The following is a description of a gene set: species: Homo sapiens In this study, we examined differential gene expression in naïve human CD4+ T cells, as well as in effector Th1, Th17-negative and Th17-enriched CD4- T cell subsets. We observed a marked enrichment for increased gene expression in effector CD4+ T cells compared to naive CD4+ among immune-mediated disease oci genes. Within effector T cells, expression of disease-associated genes was increased in Th17-enriched compared to Th17-negative cells. We used microarray to examine the gene expresssion profile and level of human naïve, Th1 and effector T cell subsets. from publication Zhang W, Ferguson J, Ng SM, Hui K, Goh G, Lin A, Esplugues E, Flavell RA, Abraham C, Zhao H, Cho JH (PMID 22715389) Human Gene Set: GSE32901_TH1_VS_TH17_NEG_CD4_TCELL_DN Genes down-regulated in CD4 T cells: Th1 versus Th17 negative., and this is the list of marker genes: TUBD1, TNFAIP8, IGHG3, HSD17B7, FAM43A, MSRB2, BCAR3, LY6G5C, HTR6, LY6D, MRPL55, DYNLT2B (dynein light chain Tctex-type 2B), INTS2, SLPI, DRP2, CHMP4C, CBX5, ACP1, CASP4, MX1, USP26, MPV17, MS4A3, CDC20, CD24, KRTAP5-4, PDZRN4, ADSS1, CCDC184, ADORA2B, SLC5A3, CAPG, CLN5, MIR187, CPLX3, KRTDAP, MOV10L1, SSX2IP, BACE2, HPGDS, IRAG2, KRT24, SWAP70, HLF, DNAJC5G, TMOD2, RHOU, BID, GPR68, LY86, EGR2 (early growth response 2), TLE1, ADGRB1, COPZ2, TMEM126A, NDC80, MARCKSL1, RFC2, NAPSA, DMPK, IL1RAPL2, DNAJC22, GSTM1, CKS1B, CLMN, DSTN, CES1, NPS, CD163L1, PGK2, UPP1, GPR37, CFAP44, NASP, CCL4, GPR137C, NELFCD, JPT2 (NCBI Gene Id 90861), MIR212, SLITRK3, FIGNL1, ARL2, ZCWPW2, FASTKD3 (NCBI Gene Id 79072), DNAJB2, CWH43, CD19, CDCA8, FAM167B, SEMA4C, MYL1, TNFSF9, SNORA19, DCC, EME1, NTRK3, RAD54L, PHEX, CD79A, NELL1, USHBP1, FCMR, MIR370, SLC4A4, CNP, SH3TC1, KCNJ15, SCN3B, ITPRIPL2, TIGD5, GDF6, ACOT11, OPN5, PGRMC2, CD83, PDCD1, UNC13B, TMEM26, CCL3, MUC5B, SVIP, SNF8, LAGE3 (L antigen family member 3), LPO